The following is a description of a gene set: Human Gene Set: GOBP_REGULATION_OF_MORPHOGENESIS_OF_A_BRANCHING_STRUCTURE Any process that modulates the rate, frequency, or extent of branching morphogenesis, the process in which the anatomical structures of branches are generated and organized. species: Homo sapiens, and this is the list of marker genes: AR, LGR4, FGFR2, SFRP1, SNAI2, SIX2, SHOX2, RTN4, FGFR1, FGF10, ESR1, CAV3, HGF, ETV5, SMO, SIX4, LHX1, TGFB1, CTNND1, FKBPL, CTNNB1, FGF7, LRRK2, AGT, TACSTD2, PAX8, SULF1, SOX8, PHB2, WNT2, BTBD7, SIRT6, BCL11A, MDK, WNT5A, BMP7, SOX9, SHH, GDNF, TNF, AGTR2, HOXD13, MAP3K13, FGF2, NTN4, BMP4, WNT2B, VEGFA, MAGED1, ABL1, SIX1, PDGFA, GREM1, HOXB7, NOG